Given this list of marker genes Acox2, Hao1, Pex6, Crat, Pex26, Acot1, Baat, Ube2d3, Ech1, Acox1, Acot3, Ube2d2a, Pex12, Gstk1, Pex2, Tysnd1, Ubc (NCBI Gene Id 77003), Cat, Acot8 (NCBI Gene Id 170789), Amacr, Pex14, Pex1, Hacl1, Nos2, Pipox, Dhrs4, Zfand6, Acaa1b, Ddo, Usp9x, Uba52rt (ubiquitin A-52 residue ribosomal protein fusion product 1, retrotransposed), Dao, Ide, Agxt, Pecr, Pex13, Hmgcl, Mlycd, Acot4, Ubb, Gnpat, Nudt19, Nudt7, Rps27a, Pex7, Lonp2, Scp2, Pex10, Ube2d1, Pex5, Eci2, Acot2, Slc27a2, Ehhadh, Hao2, Idh1, Paox, Uba52, Decr2, Ephx2, Mpv17, Phyh, Acot5, Acox3, Hsd17b4, Crot, here is a description of the gene set: species: Mus musculus Mouse Gene Set: REACTOME_PEROXISOMAL_PROTEIN_IMPORT Peroxisomal protein import